Given this list of marker genes CTLA4, STAT1, CASP10, FOXP3, FASLG, RAG1, ITCH, DOCK11, RFXANK, PGM3, SASH3, ICOS, FCGR3B, TPP2, PIK3CG, RFX5, FAS, STAT3, PNP, RFXAP, CIITA, here is a description of the gene set: Autoimmune neutropenia Abnormal decrease of the absolute number of neutrophils in the blood, per microlitre, compared to a reference range for a given sex and age-group, accompanied by the detection of anti-neutrophil antibodies. studied in species Homo sapiens Human Gene Set: HP_AUTOIMMUNE_NEUTROPENIA